The following is a description of a gene set: Human Gene Set: HP_UTERINE_LEIOMYOMA The presence of a leiomyoma of the uterus. Uterine leiomyoma species: Homo sapiens, and this is the list of marker genes: SMARCB1, LZTR1, CDC73 (cell division cycle 73), COQ6, FH, NF2, FGFR3, MSH3